Given this list of marker genes MRPL9, CNOT3, ILF2 (interleukin enhancer binding factor 2), SDHA, MRPL28, HNRNPAB, AFG3L2, PIGC, METAP1, ILVBL, DCTN2, GGCT, TMBIM6, SLC4A2, POLE3, GPAA1, PUF60, FAM120A, PSMD7, COPS5, CENPB, FBXW11, AP3S1, CYC1, ACTL6A, SERP1, SET, AKR7A2, SPCS2, ARFGAP2, SUMO1, SRP9, HDAC2, XPO7, MTDH, POLR2I, CFDP1, F8A1, ZZZ3, KHDRBS1, CS, KARS1, SLC35A1 (solute carrier family 35 member A1), RAB6A, PPM1G, RPA1, DRG1, MAML1, PHF3, TCEA1, TIAL1, KDELR1, NONO, BCAP31 (B cell receptor associated protein 31), PPP1R7, SARS1, PWP1, DOCK3, LYPLA1, COIL, ENSA, CANX (calnexin), RAD21, TMEM106C, XPOT, SART3, SNRPA, SEM1, COX5A, NCBP2, TUFM, UBAP2L, NSDHL, NUP188, MRPS18B, PDAP1, PRKAG1, CTDNEP1, NUP62, XPO6, ARF3, SMARCD2, PPP2R1A, SOD1, SMG7, SNRNP200, PSMB2, PSMB4, MTA1, MTCP1, SHMT1, BANF1, MAP2K2, ATG12, FIBP, RAC1, NDUFV1, RAD23B, PSMB6, PABPN1, PRKAR1A, here is a description of the gene set: Human Gene Set: MORF_MTA1 species: Homo sapiens Neighborhood of MTA1 Neighborhood of MTA1 metastasis associated 1 in the MORF expression compendium